The following is a description of a gene set: studied in species Homo sapiens A reduction in the amplitude of sensory nerve action potential in distal nerve segments. This feature is measured by nerve conduction studies. Decreased distal sensory nerve action potential Human Gene Set: HP_DECREASED_DISTAL_SENSORY_NERVE_ACTION_POTENTIAL, and this is the list of marker genes: NEFL, RFC1, HK1 (hexokinase 1), GDAP1, MPV17, TRPV4, LITAF, SBF2, MORC2